The following is a description of a gene set: Human Gene Set: REACTOME_IMMUNOREGULATORY_INTERACTIONS_BETWEEN_A_LYMPHOID_AND_A_NON_LYMPHOID_CELL species: Homo sapiens Immunoregulatory interactions between a Lymphoid and a non-Lymphoid cell, and this is the list of marker genes: TRAV19, IGKV1-17, IGKV2-30, IGKV4-1, IGHV3-33, IGKV2-28, SIGLEC7, SELL, IGKV1-39, IGLV3-1, CD300LD, KIR2DL4, ICAM3, LILRB5, IGHV4-59, CD3E, OSCAR, SIGLEC10, KLRC1, TRBV12-3, IGLV1-40, SIGLEC1, COL1A2, IGHV4-39, IGLV3-19, PVR, IGLV1-51, COL17A1, FCGR2B, CLEC2D, SH2D1A (SH2 domain containing 1A), IGHV2-70, IGKV1-12, IGLV1-44, CD200, CD33, JAML, IGKV2D-28, ICAM1, CD300LB, ITGB7, IGHV3-48, KIR3DL1, IGKV5-2, IGLV3-21, CLEC2B, VCAM1, LILRA3, SIGLEC11, CD8A (CD8 subunit alpha), IGHV3-53, KLRF1, SIGLEC9, IGHV4-34, CD226, KLRG1, IGLV2-8 (NCBI Gene Id 28817), IGLC3, SH2D1B, SFTPD, TRAV29DV5, LILRA4, CLEC4G, IGKV1D-16, C3, NPDC1, CD40LG, IGLV3-25, TREML2, SLAMF6, IGHV2-5, ITGB1, MICB, IGKV1D-33, HLA-G, CD34, IGKV3D-20, TREML4, CD3D, CRTAM, PIANP, CDH1, CD247, PILRB, IGLV1-47, KIR2DL1, IGLV3-27, CD40, IGHV3-11, IGLV6-57, LILRA5, IGHV1-46 (immunoglobulin heavy variable 1-46), IGKV2D-40, IGLV2-14, HLA-A, CD300LF, SIGLEC8, CD300LG, LILRB3, LILRB2, IGKV1-5, IGKV3-11, KIR2DS1, CD160, HLA-B, PILRA, IGHV3-13, IGHV3-23, ITGB2, SIGLEC6, CD300C, CD300E, CD96, LILRA2, NCR3LG1, KIR2DL2, LILRB4, TREML1, CD300A, LILRA6, FCGR3A, SIGLEC5 (NCBI Gene Id 8778), IGLV2-11, TRBV7-9, IGKV3-20, CD1D, CD1B, KIR2DS2, KLRD1, IGKV1D-39, IGHV1-2, CD22, ULBP1, NCR2, TREM1, IGHV1-69, CD1C, LAIR2, CXADR, ULBP3, COLEC12, ITGAL, HLA-F, COL3A1, CD99, NCR1, SLAMF7, CD81, MADCAM1, CD3G, COL1A1, IGKV1D-12, ICAM2, IGLV2-23, MICA, IGKV3-15, CD1A, LAIR1, NECTIN2, TRAV8-4, RAET1E, HLA-C (NCBI Gene Id 5674), HCST, IGLC2, COL2A1, IGLV7-43, KIR2DL3 (NCBI Gene Id 51344), TREM2, NCR3, ITGA4, B2M, IGKV1-16, ICAM4, FCGR1A, CD200R1, IFITM1, IGKV1-33, SIGLEC12, KLRB1, CD19, TYROBP, IGHV3-7, CD8B, LILRA1 (NCBI Gene Id 11024), KLRK1, ICAM5, IGKV2D-30, LILRB1, KIR3DL2, IGHV3-30, HLA-E